The following is a description of a gene set: Any process that activates or increases the frequency, rate or extent of the immune response, the immunological reaction of an organism to an immunogenic stimulus. species: Mus musculus Mouse Gene Set: GOBP_POSITIVE_REGULATION_OF_IMMUNE_RESPONSE, and this is the list of marker genes: Rap1a, Cd28, Il1r1, C1qb, Irf1, Tbk1, Plcg2, H2-Q4, Nfkb1, Nckap1l, Lsm14a, Trim30c, Tlr6 (toll-like receptor 6), Rnf31 (NCBI Gene Id 85306), Ankrd17, Reg3g, Trim25, Clpb, Ifih1, Fcrl5, Il12b, Mavs, Ipo5, Btn1a1, Oas1c, Dhx9, Pik3r1, Pja2, Trim32, C1rb, Il21, Ifi203-ps, H2-M1, Sarm1, Fyn, Usp9x, Il4, Slc39a10, Brcc3, Mmp12, Ncr3-ps, Gbp5, Ifi208, Exosc3, Fpr-rs6, Rapgef1, Tlr8, Spsb3, Prnp, Klrd1, 2410137M14Rik, Ppp6c, Hras, Usp50, Klrc2, Fcnb, Ighg2b, Pspc1, Appl2, Lgr4, Card11, Cd276, Lypd11, Tirap (toll-interleukin 1 receptor (TIR) domain-containing adaptor protein), Zdhhc4, H2-T24, Gps2, Tlr1 (toll-like receptor 1), Pde4d, Zfp683, Nr4a3, Fcer1a, Btnl12, Klrk1, Cd79a, Tlr5, Vtcn1, Grb2, Rigi, Kcnn4, Inava, Cyba, Card9, Akirin2, Shld3, Lrch4, Cd44, Tfrc, Blvra (NCBI Gene Id 70105), Lamp2, Mefv, Atat1, Brd4, Ltf, Cd55b, Cd59b, Rab29, Susd4, Ceacam1, Dusp3, Rsad2, Klk5, Lat2, Nfkbil1, Fbxl2, Nlrx1, Alpk1, Il17a, H60b, H2-M10.6, Cd40lg, Ube2n, Oasl1, Mad2l2, S100a9 (NCBI Gene Id 99917), Spi1, Zbp1 (Z-DNA binding protein 1), Khdrbs1, F2rl1, Pvr, C1qc, H2-M10.2, Irak1, Zc3h12a, Ninj1, Trim31, Itch, Zdhhc9, Sqstm1, Znrf1, Fcho1, Tyk2, Prkcz, C1s2, Il12a, Cd1d2, Icosl, Trim12a (NCBI Gene Id 76681), Ubash3a (ubiquitin associated and SH3 domain containing, A), Abl1, Il6, Gbp3, Clnk, H2-M5, Zdhhc3, Fcer1g, H2-K1, Trat1 (T cell receptor associated transmembrane adaptor 1), Trav7-2, Cfp, Ube2k, Fpr1, Skint3, Cmtm3, Fpr-rs3, Braf, Wdfy1, Tnfsf13, Cadm1 (NCBI Gene Id 80622), Nlrp1b, Ywhag, Cd160, Kmt5b, Tgfb1 (NCBI Gene Id 21803), Btnl9, Nfkbiz, Map3k7, Nsd2, Trim3, A2m, Kcnj8, Treml4, Gdi1, Otulin, Gpr33, Skint8, H2-M2, Oas1e, Cmklr1, Dpp4, Stat5b, Srebf1, Tnf, Ighg3, Mbl2, Rara (retinoic acid receptor, alpha), Lyplal1, Gpld1, Wnk1, Btnl1, Lats2, Fcna, Cr1l, H2-DMb1, Irak2, Ereg, Dusp22, Cd274, Lgals9, Banf1, C8b, Cd2ap, Eif2ak4, Ido1, Prkaa1, Ubr2, Epg5, Fosl2, Rnf34, Dgkz, Fyb2 (FYN binding protein 2), Lyn, Fcgr1, B2m, Klrc3, Cd1d1, Ermap, Nlrp6 (NCBI Gene Id 101613), Cfb (complement factor B), Ifi214, Ifi209, Oas1d, Irf2, Socs5, Rps6ka3, Cd300lf, Peli3, Slc11a1, Eif2b2, Elp6, Klk7, Lrrfip2, Zap70, Trim56, Slamf6, Jak2, Peli1, Ywhae, Bmx, Raet1d, Cd300a, H2-T15, Cd24a, Oas1h, Hsp90aa1, Prkd1, H2-T13, Pram1 (NCBI Gene Id 378460), Ecsit, C1s1, Tlr7, Gramd4, Ddrgk1, Il18r1, Clcf1, C3, Ptprs, Park7, Zc3hav1, Klri2, Stx7 (NCBI Gene Id 53331), Ada, Cfi, Bpifb1, Gpatch3, Gbp7, Rftn1 (NCBI Gene Id 76438), Psen1, Il2 (NCBI Gene Id 16183), Phb2, Masp2, Ikbkg, Ccdc134, Rps3, Lypd10, Il18rap, Nr1d1, Nlrp10, Skint9, Malt1, Cblb, Xiap, Skint11, Tlr4, Il27ra, Sppl3, Zdhhc12, Trex1, Foxp3, Ubqln1, Prkd2, Chuk, Rnf115, Colec10, Lta, Sirt2, Zp3, Pik3ap1, Nlrc5, Rbm14, Stmp1, Trim11 (NCBI Gene Id 94091), Gfi1, Trim30a, Txk, Rc3h1, Themis, H2-T3, Cacnb3, Ifnl3, Fpr-rs4, Tasl, Colec12, Kars1, D1Pas1, Blnk, Nfatc2, Shld1, Gbp2b, Skint6, Bcl2, Fyb1, Hexim1, Gimap5, S100a14, Prkdc, Nmi, Lat, Ticam2, H2-M9, Mbl1, Il15, Fcgr3, C2, Rab11fip2, Ptprc, Pum2, Xbp1, Esr1, Cd38, Exosc6, Rabgef1, Plcl2, Ifi211, Naglu, Ppt1, Cd8b1, Nono, Znrf4, Ifi203, Gpr108, Stx4a, Polr3c, Lrrc14, Traf3, Ms4a1, Cd55, Irgm1 (immunity-related GTPase family M member 1), Sla2, H2-M3, Parp9, Igtp, H2-Eb1, Ifi204, Zdhhc5, Gcsam, Ep300, Aim2, Lilrb4a, Nagk, Xcl1, Skint5, Lilrb4b, Cfd, Pvrig, Gimap3, Lcp2, Itgam (integrin alpha M), Ffar2 (NCBI Gene Id 233079), Tspan6, Usp29, Lpxn, Klrb1c, Sh2d1b1, Cd46, Polr3b, Lbp, Carmil2, Plekha1, C4a (NCBI Gene Id 625018), Rbm47, Bax, Hcfc2, Skint2, Il12rb1, Krt1, Psen2, Btn2a2, Rif1, C4b, H2-Q10, Cd14, Thy1, Rps19, Nfam1, Tlr13, Pck1, Tnip2, Phpt1, H2-Q7, Rnf125, Mapkapk2, Stoml2, Kmt5c, Stk11, Matr3, Ddx3x, Shb, Fpr-rs7, Cd300ld2, Irf4, Cgas, Myd88, Mapk8, Tifab, Trim30b, H2-Oa, Cd226, Cfhr1, Stat5a, Ifi213, Ccr7, Shld2, Rbck1 (RanBP-type and C3HC4-type zinc finger containing 1), Mir326, H2-Q6, Traf6, Sh2b2, Nck1, Hspa1b, Nfkbia, Lax1, Clec4e, Trim5, Ppp2ca, Blk, Cacnb4, Igha, Tec, Tap2, Usp15, Mif, Fosl1, Ogt, Aurkb, Ufd1, Tab1, Il10, Klhl22, S100a8, Oas1a, Ccr2, Polr3g, Dhx58, Zdhhc1, Btk, Nod1, Cd40, C1ra, Oas3, Itpripl1, Traf2, Phb1, Hmces, Bcar1, Skap1, Tarbp2, C1qa, Casp6, Appl1, Sh2d1a, Cd3e, Mark4, Riok3 (RIO kinase 3), Oas1b, Slc39a6, Pycard, Hc, Ctla4, Cd47, Hmgb2, Sash3, Oas1g, C5ar2, Tmem126a, H2-Ab1, Dhx33 (DEAH-box helicase 33), Nr1h3, App, Lacc1, Sec14l1 (SEC14-like lipid binding 1), Vav3, Lag3, Slamf1, Opa1, Nr1h4, Havcr2, Cd79b, Vav1, Prkch, Rnf135, Cd300lb, Tnfrsf21, Cactin, Tril, Itgb2l, Akt1, Rnf185, Nos2, Ap1g1 (adaptor protein complex AP-1, gamma 1 subunit), Parp1, Tax1bp1, Prkcb, Brcc3dc, H2-M11 (histocompatibility 2, M region locus 11), Ptprj, C1rl, Btnl10, Hmgb1, Il18, Acod1, Lime1, Cfhr4, Tnip3, Usp12, Ulbp1, Mfhas1, Elane, Atad5, Wnt5a, Cfh, H2-DMb2, Ighg1, Slc46a2, Arf6, Pagr1a, Mapkapk3, Eif2b4, Ifi205, Arrb2, Il23r, C8g, Vsig4, C9, Letmd1, Skint4, Pum1, Pqbp1, Ctsg (NCBI Gene Id 13035), Il4ra, Bag6, C3ar1, Fpr3, Rela (NCBI Gene Id 19697), Elf1, Mir301 (NCBI Gene Id 723834), Brd2, Paxip1, Klre1, H2-Ea, Sirt1, Sphk2, Themis3, Trp53bp1, Mef2c, Tmigd3, Becn1, Ddx60, C8a, Itk, Tkfc, Irgm2, Slc15a3, Otud4, Sting1, Nploc4, Ikbke, Zp3r, Ifi207 (NCBI Gene Id 98407), Il23a, Btnl2, H2-DMa, Tnfsf4, Btrc, Pawr, Fzd5, Crkl, Lipa, Gata3, Ifi206, C4bp, H2-T5, Csk, Btnl4, Lck, Anxa1, Rgcc, Rnf144a, Serping1, Raet1e, Slc15a4, Lats1, Fadd, H2-Q2, Gpr31b, Eif2b5, Tgfb2, Colec11, Cd81, Klrc1, Ighg2c, Casp1, C7 (NCBI Gene Id 636878), Ptpn6, H60c (histocompatibility 60c), H2-T23, Tespa1, Irf7, Gbp2, Ripk2, Cd300ld4, Pdpk1, Cpt1a, Tlr11, Tnfsf13b, Lgals3 (NCBI Gene Id 16854), Ap3b1, Cd36, Ticam1, Pten, Crtam, Hrg, Tnfaip3, H2-Q1, Trim30d, Trim15, C1qbp, Ccl19, Kat5, Prkce, Foxp1, H2-M10.3, Znfx1, Src, Clec7a, Gkn2, C6, Syk, Fcmr, Sin3a, Trem2, Cd4, C5ar1, Ifnl2, Cd74, Fbxo38, Il33, Gm12250, Crp, Ptgs2os, Nop53, Fcer2a, Cd59a, H2-Eb2, Trim41, Xrcc6, H2-T22, Klri1, Skint10, Mlh1, Tlr2, Tlr12, Masp1, Kcnk13, Tlr9, Sos1, Cd177, Irak3, Itgb2, Dab2ip, Il17f, Bcl10, Trim62, Oas1f, Rab7b, Cd22, Cyrib, Plscr2, Fpr2, Hpx, Zdhhc18, Slc15a2, Mapk1, Flot1, Nectin2, Nlrp1a, Plcg1, Eif2b3, Gm15441, Cd247, Smpdl3b (NCBI Gene Id 68772), Bcl2a1d, Il1b, Azgp1, Stap1, Ptpn2, Ighe, Themis2, Scimp, Rasgrp4, Nod2, Cd19 (CD19 antigen), Cd8a, Casp4, Rc3h2 (NCBI Gene Id 77277), Ly96, Arid5a, Nfkbid, Tyrobp, Rnf170 (NCBI Gene Id 77733), Eif2ak2, Cptp, Mndal, Clec2i, Plscr1, Ezr, Ifi35, Nlrc3, Cnr1, Cr2, Xrcc5, Lrrc19, Traf3ip3, Polr3f, Slc19a1, Prkcq, Mr1, Btnl6, Irf3, Ighm, H2-Aa, Pgc, Tnfrsf13c, Usp17le, Unc93b1, Skint7, Rasgrp1, Pde4b, Sfpq, Usp27x, P2rx7, Dennd1b, Usp46, Nek7, Cd86, Csnk1a1, Pnp, Washc4, Klhl6, Clec4n, Pla2g5, Adam8, Trim12c, Cd300ld3, Trem3, H2-M10.5, Ptpn22, Zcchc3, H2-M10.4, Tlr3, Tnip1, Tbx21, Med1, Erbin, Gsdme, Rtn4, Abhd17a, Msh2, Cav1, Nras, Ifng, Hspa8, Eif2b1 (NCBI Gene Id 52255), Cd5l, Hlx, Cyld, Cfhr2, Lamp1, Polr3d, Myo1g, Mog, Ptafr, 6030468B19Rik, Smpdl3a, H2-Ob, Slc22a13, H2-D1, Aars2, Pcbp2, Hspd1, Pms2, Sh2d1b2, Tifa, Nlrp3, Tomm70a, H2-M10.1, Trim6, Stat6, Skint1, Nlrc4, Tyro3, Cd300ld, Pla2g4a, Laptm5, Zbtb1 (zinc finger and BTB domain containing 1)